The following is a description of a gene set: Human Gene Set: TAF9B_TARGET_GENES species: Homo sapiens Genes containing one or more binding sites for (TAF9B) in their promoter regions (TSS -1000,+100 bp) as identified by GTRD version 20.06 ChIP-seq harmonization. from publication Yevshin I, Sharipov R, Kolmykov S, Kondrakhin Y, Kolpakov F (PMID 30445619), and this is the list of marker genes: GRIPAP1, CRAT, PTEN, TOMM22-DT (NCBI Gene Id 124905117), ARMCX5, BEX4, RNVU1-4, NDUFAF1, RPL37A, SLC1A5, HMG20A, REXO4, CHEK1, MRPL35, CTNNB1, CPED1, TYW5, ELP4, MCPH1-AS1, PCF11, TRIP12, RPS24, TMEM242, COQ9, RPL29, MED28-DT, MRPL39, EHD1, EIF4E, ENSG00000266401, PTMA, COX7A2, TMEM242-DT, HUS1, GBE1 (1,4-alpha-glucan branching enzyme 1), OGDH, MAST2, DCAF15, NDUFC2, SEC22B, RNU5A-1, POLR2C, RPL23A, BBS1 (Bardet-Biedl syndrome 1), ENSG00000266976, CLCN3, WDR74, SNORD95, BIN1 (bridging integrator 1), PRECSIT, RNU4-1, UBAC2, SNORD15A, H4C8, TMEM140, MTF2, H2AZ1 (NCBI Gene Id 3015), LINC00938, ZNF561-AS1, SNHG15, NCAPH2, AFF1, YWHAE, IMMP1L, MAF, TGDS (NCBI Gene Id 23483), NEAT1, RBM34, MDH2, XIST, EIF4B, IKBKG, BICRAL (NCBI Gene Id 23506), POLR1H, NCSTN, BMS1, CENPP, TFRC, SNORD25, ZNF675, SF3B3, DNAJB2, SNHG6, ARPC5L, INTS6, NDUFA4, LINC01610, ADH5, CYREN, ENSG00000249713, NDUFC1, AZIN1, THOC2, PICALM, TRIP4, UBE3B, MNAT1, TRAPPC8, ZNF518A, RPL17, HNRNPH3, ISLR2, C5orf34 (NCBI Gene Id 375444), ZEB2, CHCHD2P1, PCIF1, RCOR1, RPS3, FXR1 (FMR1 autosomal homolog 1), EEFSEC, RNVU1-15, SLC4A1AP, E2F3, LIMD1, ZSCAN16-AS1 (NCBI Gene Id 100129195), KCTD5, USP3, ATG12, USP9X, SUGCT, MIA3, NOL8, SNHG17, RPL39, KLF10, RHCE, RPL4, CASC9, DR1, SEC62 (NCBI Gene Id 7095), MMP11, LMAN1 (NCBI Gene Id 3998), RPL17-C18orf32, UBE2O, RNVU1-19, UFC1, MCL1, LINC01169, SNORD58B, FNBP1P1, ALKBH3-AS1, LINC03059, STX16-NPEPL1, FLJ46284, GOSR1, UBAC2-AS1, BTG1-DT, SLC9A1, MRPL42, CRNDE, AP3S2, VPS25, TM9SF4, ECE2, NDUFS4, PNRC2, LRSAM1, ZNF391, SNORD43, MAPK6-DT, RNVU1-26, NEK4, ENSG00000259182, RNU2-17P, AMMECR1, MAPK6, TAF6, MRPL13, RNVU1-31, RPL34 (ribosomal protein L34), PHRF1, CCDC121, KMT2D, RPSAP28, ENSG00000273727, CCT4, NDUFA7, RANBP3-DT, MCRIP1, USF2, STAG2, RNF121, ZNF343, HEXIM2-AS1, RNU5E-6P, CEP20, RPL35A, GSTCD, COX10, ENSG00000187186, TBC1D10A, MAILR, OGT, ALG3, MIR3681HG, SIX5, SNHG32, ENSG00000246090, NET1, RPL12, NELFA, SLC30A6 (solute carrier family 30 member 6), STX16, SPTA1, SMIM20, CCDC8, RNU5B-1, RPL37A-DT, MORF4L2, ENTR1, NSFL1C, RPS6, RBM15, TBL1X, ZBTB37, CCNI, TEFM, TM2D1, ST7L, NDUFC2-KCTD14 (NDUFC2-KCTD14 readthrough), TAF5, ANKMY2, PTPA, NR1H3, LINC01275, FHL1P1, HDLBP, SNORD48, ARMC8, NLRP1, SPTLC1, RSL1D1-DT, PFDN4, GAS5, RBM27, ZCCHC10, RPL31, CCNL1, GANC, ATF1, HSP90AB1, ATP5MF, INTS12, RPL41, MMADHC, STK17B, RNU6ATAC32P, PSMB6, LINC01270, MACO1, ANXA5, NDUFA12, XNDC1N, ZNF257, MYO9B, BAGE2, LINC02428, ACADM, SUB1, SAMSN1, NSUN4, GADD45A (growth arrest and DNA damage inducible alpha), LINC02476 (NCBI Gene Id 105375475), MORF4L2-AS1, KCTD10, SCFD1, CIAPIN1, MIR22HG, ACTR3 (NCBI Gene Id 10096), B3GALT1-AS1, ZNF770, RPL6, MALAT1, EEF1A1, FBXO36 (NCBI Gene Id 130888), STAT1, AAR2, TATDN3, RPL7A, MRPL20, KLHL20, RANBP3, USP28, LINC02577, GTF3C3, TOMM22, SERBP1, FAM204A, SPRED2, SAT1-DT, RPL5, TJAP1, SNORD42B, RPL38, BACH1, FTX, ZSCAN12, RNU11, PSMD8 (NCBI Gene Id 5714), PER1, APLP2, KBTBD4, LZIC, NMT1, ADAP2, COPA, CCNC, MED4, TOPORS, FOXJ3, SGMS1, RNVU1-22, ID1, BHLHE40, FAM98B, GFI1B, PPP4R3A, RAB7A, UBE2L3, RNU7-27P, SNORD26, PNP, SEPTIN2, ZMAT2, ACP2 (NCBI Gene Id 96117), RPL7, SUPT7L, USP21, CRTC1, PAXBP1 (PAX3 and PAX7 binding protein 1), EPCIP-AS1, RPRD2, MIR5087, SLC3A2, CD63-AS1, BZW2, SPESP1, POLR1HASP, ELOB, FBXO28, AKR1C1, DPY30, SAT1, DCAKD, RNU2-2P, MKRN3, RICTOR, CAPZA1, HIF1A, PSMD12, ATP5MF-PTCD1, DNAJB4, MTBP, AP3S1, ZBTB45, PMPCA, ZNF561 (zinc finger protein 561), SELENOF, ZC3H6, CDK12, PCLAF, RPL10A, MIR548AW, RNU5E-4P, TACO1, HJV, NDUFS3, ZC3HC1, SNRNP27, RPL3, IGSF1, COPZ1, INTS5, CYCS, PLCB1, CHM, AGPAT4, SEC24C, LRCH3, INTS6-AS1, PDXK, SF3A3, SNHG1, SMG8, ARID1A, KNTC1, IQGAP2, MBTPS2, ELP3, MCU, ZNF629, PABPC1 (poly(A) binding protein cytoplasmic 1), ID2, PSAP, HMGCL, ATP5F1B, RNVU1-2A, TMBIM6, MED28 (mediator complex subunit 28), ATRX, EIF2D, LINC01287, CARS1, RPL28, LINC00958, ETAA1, SNORD27, KDM5C, GTF3C5, FAM133B, RPS29, RACK1, LINC00431, CNPY4, TOP3B, RSRC2, GTF2H3, RNU5D-1, BABAM1, MBD6, COMMD1, ANP32A, ZWILCH, DDX19B, CSMD1, ATP6V1B2, RPL13A (NCBI Gene Id 94020), GNL3, ODC1, RPL11, ODC1-DT, TBC1D19, ABHD2, FCRLA, ZSWIM6, SLC15A4, TRUB1, ACTR8, RPS15, ZZZ3, NMNAT1, TXN, LINC01531, HAUS8, LMF2, RPL26, RNVU1-25, LINC01088, PHIP, HOXB9, G2E3-AS1, RPL14, BCAN-AS2 (NCBI Gene Id 126568844), COX10-DT, RPL10, CSNK1G3, MED22, TAF2, EIF1AD, SMIM27, RPS14, EIF4A2, PBRM1, RPL34-DT, DDX1, TGIF1, RPL7L1, PCNP, ANKRD17, PCCB, CLASP1, RPL27 (ribosomal protein L27), BTG1, ZNF626, DRG2, MAIP1, CCDC88A, SEL1L3, FTL, ZEB2-AS1, HEXIM2 (HEXIM P-TEFb complex subunit 2), S100A2, ARHGEF6, DNHD1, TMEM87A, TANK, CCDC18-AS1, H2AZ1-DT, ENSG00000275740, PARP12, TMT1A, RPS27, COG4, PSMC3, MEIS2, AARS1, PLEKHM3, BANF1, PEAK1, RNU4ATAC, NDUFS2, SAMD4A (NCBI Gene Id 26078), CARD8, EIF3D, KCNQ1OT1, IQCG, MRPS31P5, EEF1G, EPOR, BRF2, RBX1, NSRP1, KLLN, NORAD, RSL1D1, MIX23, IGF2BP3, RNVU1-21, NAGK, SAR1B, TFAP4, TBCC, TRIB3, DDIT3, APOL2, ID2-AS1, CD63, CHCHD10, RPTOR, PTCD1, RNVU1-34, TIMM22, HCG21, MRPS10, CNOT4, RPS28, NOP53, ARL4A, TRIP11, STYXL1, RN7SL1, ACBD6, NSL1, BRWD1, SNHG5, RPL35 (ribosomal protein L35), ENO1-AS1, TXNDC15, RBM28, TANK-AS1, HOXB-AS1, PUM1, TSC1, RPS4X, ANP32E, SFTA2, MPLKIP, EIF2B1, LIN9, RNVU1-28, EEF2, STMP1, FAM162A, PIGL, RNVU1-2, KAT6A, HOXB2, RBM15-AS1, SNORD59A (small nucleolar RNA, C/D box 59A), MIR4435-2HG, GPN1, KRR1, SLC30A6-DT, HS2ST1, SSX1